Given this list of marker genes Dysf, Gpd2, Tkfc, Pck1, Gk2, Tpi1, Gk, Gk5, Gykl1, Pla2g4a, Mogat1, Dgat2 (NCBI Gene Id 67800), Lep, Pgp, Got1, Coq3, Mogat2, Angptl3, Coq2, Myof, Pck2, here is a description of the gene set: Mouse Gene Set: GOBP_GLYCEROL_METABOLIC_PROCESS studied in species Mus musculus The chemical reactions and pathways involving glycerol, 1,2,3-propanetriol, a sweet, hygroscopic, viscous liquid, widely distributed in nature as a constituent of many lipids.